The following is a description of a gene set: Reactome Pathway: Signaling by NOTCH2 studied in species Homo sapiens NOTCH2 is activated by binding Delta-like and Jagged ligands (DLL/JAG) expressed in trans on neighboring cells. In trans ligand-receptor binding is followed by ADAM10 mediated and gamma secretase complex mediated cleavage of NOTCH2, resulting in the release of the intracellular domain of NOTCH2, NICD2, into the cytosol. NICD2 traffics to the nucleus where it acts as a transcriptional regulator. For a recent review of the cannonical NOTCH signaling, please refer to Kopan and Ilagan 2009, D'Souza et al. 2010, Kovall and Blacklow 2010. CNTN1 (contactin 1), a protein involved in oligodendrocyte maturation and MDK (midkine), which plays an important role in epithelial-to-mesenchymal transition, can also bind NOTCH2 and activate NOTCH2 signaling.<br><br>In the nucleus, NICD2 forms a complex with RBPJ (CBF1, CSL) and MAML (mastermind). The NICD2:RBPJ:MAML complex activates transcription from RBPJ binding promoter elements (RBEs). NOTCH2 coactivator complexes directly stimulate transcription of HES1 and HES5 genes, both of which are known NOTCH1 targets. NOTCH2 but not NOTCH1 coactivator complexes, stimulate FCER2 transcription. Overexpression of FCER2 (CD23A) is a hallmark of B-cell chronic lymphocytic leukemia (B-CLL) and correlates with the malfunction of apoptosis, which is thought be an underlying mechanism of B-CLL development. NOTCH2 coactivator complexes together with CREBP1 and EP300 stimulate transcription of GZMB (granzyme B), which is important for the cytotoxic function of CD8+ T cells.<br><br>NOTCH2 gene expression is differentially regulated during human B-cell development, with NOTCH2 transcripts appearing at late developmental stages.<br><br> NOTCH2 mutations are a rare cause of Alagille syndrome (AGS). AGS is a dominant congenital multisystem disorder characterized mainly by hepatic bile duct abnormalities. Craniofacial, heart and kidney abnormalities are also frequently observed in the Alagille spectrum. AGS is predominantly caused by mutations in JAG1, a NOTCH2 ligand, but it can also be caused by mutations in NOTCH2.<br><br><br>Hajdu-Cheney syndrome, an autosomal dominant disorder characterized by severe and progressive bone loss, is caused by NOTCH2 mutations that result in premature C-terminal NOTCH2 truncation, probably leading to increased NOTCH2 signaling. part of: Signaling by NOTCH, and this is the list of marker genes: PSEN1, CREB1, PSENEN, EP300, JAG1, RBPJ, CNTN1, NOTCH2NLA, ADAM10, MAML2, APH1A, NOTCH2, APH1B, DLL1, UBB, NEURL1B, FCER2, HES1, NOTCH2NLB, MDK, NEURL1, MAML3, JAG2, MIB2, PSEN2, UBC, HES5, GZMB, NCSTN, UBA52, NOTCH2NLC, MIB1, RPS27A (NCBI Gene Id 6233), MAMLD1, DLL4, MAML1